Given this list of marker genes SLC25A25-AS1, XPO5, TMC6, SMARCD1, DOCK7, ANKLE2, PTOV1-AS2, FNBP4, CLK3, SLC23A2, CDC42SE1, FURIN, TYW5, ACE, ZNF532, BTAF1, XPO6, DPH7, ECHDC1, AMY2B, MCM5, TAFAZZIN, MBD4, PODXL, PCGF6, MLXIP, ITPR3, QTRT2, SBNO2, CHEK1, ZNF436-AS1, ENGASE, QSOX2, MIR3682 (NCBI Gene Id 100500850), OFD1, LENG8, TINAGL1, CCNL1, LIMD2, CNTRL, GPC2 (glypican 2), DDX11, TJAP1, ZMIZ2, HLX, C2orf68, TOPBP1, SNAPC4, RAPGEF1, SNHG26, CCNJ, ZNF316, SET, EHBP1L1, DXO, PPHLN1, BRD2, CYTH1, ST14, FUBP1, CYBA, CHD2, ZNF142, DNHD1, DHX37, UQCC2, EHMT2, GRAMD4, KHDC4, DMD, MIRLET7D, DGKZ, NPIPB3, DNM2, FBXL19, PML, SH3BP5-AS1, WDTC1, SZT2, MSL2, ITSN2, TCOF1 (NCBI Gene Id 6949), CLASRP, TSPOAP1-AS1, RNF220, MCM3, DHX16, TLN1, GTPBP2, POLR1A, DDX39B, KDM4A, HCFC1, CCDC93, POGLUT1, RPS6KA1, KMT2E-AS1, EWSR1, PUM1, PHACTR4, MKI67, PROSER1, GBA2, TAPBP, TNFRSF25, PASK, RABGAP1 (RAB GTPase activating protein 1), BTN2A1, RNPS1, CALML4 (NCBI Gene Id 91860), MYO9B, SLC18B1, ATXN7, ACSL5, MAD2L1BP, SF1, PTBP1, SFPQ (splicing factor proline and glutamine rich), TNIP1 (TNFAIP3 interacting protein 1), LARP1 (NCBI Gene Id 91673), MADD, COG3, ITFG2, ARHGAP17, LINC01355, DAPK2, CASP4, AGO4, SUPT7L, EPM2AIP1, HNRNPH3, TEPSIN, EIF4G1, PGS1, FBXL18, PPARD, NSUN5, CAMK2G, PLXND1, MSH5, CHTOP, RAB35, PARP6, EXOC3, TCIRG1, TRA2A, NUP62, CAPN15, HSPBAP1, ASMTL-AS1, HNRNPD, TNFAIP2, DAZAP1, RUBCN, NUP214, ZNF318, PSPC1 (paraspeckle component 1), MON2, BAG6, TMEM147-AS1, DENND11, NSUN4, TSPOAP1, SMC4, PHF11, KIFC1, GRIPAP1, PRRC2A, SMC6, NSUN5P1, POLR1HASP, PABPN1, TRRAP, RBM26, CCDC77, PNN, SLC15A4, CSNK2B, SUPT20H, NAA16, HINT1, TBRG1, SRSF2, AKAP13, here is a description of the gene set: PURPOSE: Amplification of chromosomal region 20q13 occurs in breast cancer but remains poorly characterized. EXPERIMENTAL DESIGN: To establish the frequency of 20q13 amplification and select the amplified cases to be studied, we used fluorescence in situ hybridization of bacterial artificial chromosome probes for three 20q13 loci (MYBL2, STK6, ZNF217) on sections of tissue microarrays containing 466 primary carcinoma samples. We used Affymetryx whole-genome DNA microarrays to establish the gene expression profiles of 20q13-amplified tumors and quantitative reverse transcription-PCR to validate the results. RESULTS: We found 36 (8%) 20q13-amplified samples. They were distributed in two types: type 1 tumors showed ZNF217 amplification only, whereas type 2 tumors showed amplification at two or three loci. Examination of the histoclinical features of the amplified tumors showed two strikingly opposite data. First, type 1 tumors were more frequently lymph node-negative tumors but were paradoxically associated with a poor prognosis. Second, type 2 tumors were more frequently lymph node-positive tumors but were paradoxically associated with a good prognosis. Type 1 and type 2 showed different gene expression profiles. No 20q13 gene could be associated with type 1 amplification, whereas several 20q13 genes were overexpressed in type 2 tumors. CONCLUSIONS: Our results suggest that amplified tumors of types 1 and 2 are two distinct entities resulting from two different mechanisms and associated to different prognosis. from publication Ginestier C, Cervera N, Finetti P, Esteyries S, Esterni B, Adélaïde J, Xerri L, Viens P, Jacquemier J, Charafe-Jauffret E, Chaffanet M, Birnbaum D, Bertucci F (PMID 16899599) studied in species Homo sapiens Genes down-regulated in metastatic breast cancer tumors having type 2 amplification in the 20q13 region; involves MYBL2, STK6 and ZNF217 Human Gene Set: GINESTIER_BREAST_CANCER_20Q13_AMPLIFICATION_DN